Given this list of marker genes RBM4, NSRP1, RNPS1, SMU1, CELF1, TRA2B, RBM15, RBPMS2, MAGOH (mago homolog, exon junction complex subunit), NOVA2, CELF5, RBM20, HNRNPL, RBFOX1, DDX17, SRSF2, DYRK1A, REST, KHDRBS1, TIA1, WTAP, DDX5, KHDRBS3, SRSF8 (NCBI Gene Id 115898), RBPMS, ARGLU1, CELF3, HNRNPA1, RBM15B, CELF6, RBFOX2, CELF2, RBMY1A1, HNRNPU, RBMX, NOVA1, SAP18, RBM5, ARB2A (ARB2 cotranscriptional regulator A), SRRM4, SRSF12, PUF60, RBM8A, RBM11 (RNA binding motif protein 11), SRSF6 (serine and arginine rich splicing factor 6), THRAP3, PTBP1, RBM24, RBFOX3, ZBTB7A, RBM25, CELF4, MYOD1, YTHDC1, KHDRBS2, FMR1, THUMPD2, RBM7, RBM47, here is a description of the gene set: Any process that modulates the frequency, rate or extent of alternative splicing of nuclear mRNAs. Human Gene Set: GOBP_REGULATION_OF_ALTERNATIVE_MRNA_SPLICING_VIA_SPLICEOSOME studied in species Homo sapiens